The following is a description of a gene set: A process in which force is generated within striated muscle tissue, resulting in the shortening of the muscle. Force generation involves a chemo-mechanical energy conversion step that is carried out by the actin/myosin complex activity, which generates force through ATP hydrolysis. Striated muscle is a type of muscle in which the repeating units (sarcomeres) of the contractile myofibrils are arranged in registry throughout the cell, resulting in transverse or oblique striations observable at the level of the light microscope. species: Mus musculus Mouse Gene Set: GOBP_STRIATED_MUSCLE_CONTRACTION, and this is the list of marker genes: Kcnj2, Rangrf, Atp2a2, Ryr1, Grcc10 (gene rich cluster, C10 gene), Ctnna3 (catenin alpha 3), Trpv4, Scn3b, Rcsd1, Adora1, Snta1, Kcnn2, Myl4, Myh3, Myh7, Zc3h12a, Nppa, Atp1a2, Kcne3, Atp1b1, Nedd4l, Jup, Slc8a1, Atp1a1, Mtor, Myl3, Dlg1, Ccdc78, Prkd1, Calm2, Kcne4, Rem1, Psen2, Tnnc1, Lmod3, Cacnb2, Pln, Ryr3, Slc8a3, Adra1a, Scn5a, Chrng (cholinergic receptor, nicotinic, gamma polypeptide), Casq1, Adcy10, Kcnh2, Myh7b (NCBI Gene Id 674786), Kcne2, Tpm1, Pde5a, Nup155, Kcne5, Chga, Cacna1h, Gata4, Tnnt2, Stc1, Bin1, Calm1, Cacna1c, Mylk2, P2rx4, Flna, Akap9, Atp2a1, Cacna1s, Dmd, Tnf, Tnnt1, Gja5, Ryr2, Camk2d, Cacna1d, Pkp2, Actc1, 3425401B19Rik (RIKEN cDNA 3425401B19 gene), Synm, Kcna5, Kcnd3, Scn1a, Pde4d, Myl2, Tnni1, Nkx2-5 (NK2 homeobox 5), Kcnj8, Ank2, Tnnc2, Tnni3k, Cxcr4, Myh8, Sumo1, Hcn4, Tmem38b (transmembrane protein 38B), Stac (NCBI Gene Id 20840), Kcne1, Tnni3, Scn4b, Kcnq1, Large1, Agrn, Scn10a, Cacna2d1, Chrne, Gsn, Sri, Slc9a1, Tmem38a, Chrna1, Scn4a, Ccn2, Fgf13, Rps6kb1, Rgs2, Ehd3, Pik3ca, Atp8a2, Kbtbd13, Klk1b1, Srsf1, Map2k3, Scn1b, Atp1a3, Map2k6, Ace2, Scn2b, Adra1b, Gaa, Hdac4, Zfas1, Bmp10, Stac3, Nr4a1, Chrnd (cholinergic receptor, nicotinic, delta polypeptide), Uty, Csrp3 (NCBI Gene Id 13009), Sgcd, Casq2, Smtn, Ddit3, Myl1, Akap6, Tcap, Gpd1l, Vegfb, Aldoa, Jsrp1, Dsc2, Stac2, Fkbp1b (NCBI Gene Id 14226), Tnnt3, Nos1, Ppp1r13l, Cav1, Adrb2, Tnni2, Myh14, Adrb1, Trpm4, Pgam2, Homer1, Mybpc3, Hsp90aa1, Dsg2, Dmpk, Ucn, Tafazzin, Rnf207, Kcnj5, Ttn, Myh6, Cav3, Dsp, Selenon, Met, Actn3, Smad5, Calm3 (calmodulin 3), Chrnb1, Vps54, Abcc9, Smad7, Grk2, Arg2, Fxyd1, Strit1